Given this list of marker genes Trnt1 (tRNA nucleotidyl transferase, CCA-adding, 1), Kars1, Oas1h, Polg, Thg1l, Nudt5, Oas2, Yrdc, Parp10, Tut1, Pif1, Ugp2, Parp3, Art2b, Acd, Fpgt, Pola2, Cmas, Mab21l1, Papola, Ctu2, Tut7, Tep1, Oas1e, Pole, Sirt4, Polr2k, Papss1, Dkc1, Mocs3, Mtpap, Tnks2, Prim1, Tent2, Pold1, Pinx1, Polr3k, Oas1a, Polr2i, Sirt6, Flad1, Pola1, Rev3l, Poln, Tent5a, Dntt, Art3, Crcp, Terf2, Polr2j, Parp16, Uap1l1, Pold4, Tiparp, Pcna, Tnks (tankyrase, TRF1-interacting ankyrin-related ADP-ribose polymerase), Oasl2, Cds1, Polb, Art5, Polk, Tefm, Oas1g, Pcyt2, Cds2, Art4, Polr2b, Cgas, Tent5d, Primpol, Coasy, Ficd, Nmnat2, Mb21d2, Papolg, Rngtt, Chrac1, Oas1c, Parp8, Polh, Fhit, Selenoo, Polr1b, Parp11, Galt, Ctu1, Oas1f, Mcrs1, Tert, Tent5c, Gphn, Parp1, Polr1h, Gars1, Nmnat1, Terc, Oas3, Polr3a, Oasl1, Parp9, Polr3c, Art1, Parp2 (NCBI Gene Id 30876), Polr2e, Polr1d, Nmnat3, Polg2, Pold3, Polr2f, Parp6, Polr3h, Polm, Rev1, Polr2c, Poli, Rpap1, Parp14, Polr2a, Poll, Papss2, Parp4, Polr2g, Tent4a, Tamm41, Pcyt1b, Pnpt1, Polr2h, Gmppb, Parp12, Terf1, Polr1a, Ptges3, Polrmt, Polq, Ten1, Polr1c, Gdpgp1, Pot1a, Papolb (poly (A) polymerase beta (testis specific)), Oas1b, Pcyt1a (NCBI Gene Id 13026), Polr2l, Ptges3-ps, Tent4b, Polr3b, Pot1b, Oas1d, Tent5b, Uap1, Tut4, Art2a, Crppa, here is a description of the gene set: Mouse Gene Set: GOMF_NUCLEOTIDYLTRANSFERASE_ACTIVITY Catalysis of the transfer of a nucleotidyl group from one compound (donor) to another (acceptor). studied in species Mus musculus